The following is a description of a gene set: studied in species Mus musculus from publication Sheth SS, Bodnar JS, Ghazalpour A, Thipphavong CK, Tsutsumi S, Tward AD, Demant P, Kodama T, Aburatani H, Lusis AJ (PMID 16607285) The molecular pathogenesis and the genetic aberrations that lead to the progression of hepatocellular carcinoma (HCC) are largely unknown. Here, we demonstrate that the thioredoxin interacting protein (Txnip) gene is a candidate tumor suppressor gene in vivo. We previously showed that the recombinant inbred congenic strain HcB-19 has a spontaneous mutation of the Txnip gene, and we now show that the strain has dramatically increased incidence of HCC, and that the HCC cosegregates with the Txnip mutation. Approximately 40% of the Txnip-deficient mice developed hepatic tumors with an increased prevalence in male mice. Visible tumors develop as early as 8 months of age. Histological analysis confirmed the morphology of HCC in the Txnip-deficient mice. Molecular markers of HCC, alpha-fetoprotein and p53, were increased in tumors of Txnip-deficient mice. The upregulation of p53 preceded tumor development; however, bromodeoxyuridine (BrdU) labeling of normal hepatic tissue of Txnip-deficient mice did not reveal increased cell proliferation. Finally, microarray analyses of tumor, non-tumor adjacent, and normal tissue of Txnip-deficient mice highlighted the genetic differences leading to the predisposition and onset of HCC. Our findings suggest that Txnip deficiency is sufficient to initiate HCC and suggest novel mechanisms in hepatocarcinogenesis. Mouse Gene Set: SHETH_LIVER_CANCER_VS_TXNIP_LOSS_PAM2 Cluster PAM2: genes up-regulated in hepatocellular carcinoma (HCC) vs normal liver tissue from mice deficient for TXNIP., and this is the list of marker genes: Pold4, Paqr4, Lysmd2, Tubb2a, Ddit3, Abcb1a, Acbd3, Smpdl3b, Scn8a, Eif2ak3, Ccnb1, Pttg1, Slc39a4, Bex2, Myo7b, Uap1l1, Abcc5, Fkbp11, Col4a1, Runx2, Zfp119a, Arhgap18, Cd93, App, Dab1, Vamp5 (NCBI Gene Id 53620), Tagln2, Tle6, Upp1, Rrm2, Twf2, Dip2b, Psrc1, Rogdi, Clcf1, Bmp7, Heph, Slc1a4, Stt3a, Tor4a, H1f2, Wnt10a, Fmnl3, Mcam, Kcnj8, Rasgrp2, Comtd1, Zg16, Rbp1, Cyp39a1, Ptpre, Bicdl1, Fscn1, Tacc3, Xylt2, Ddx25, Nap1l1, Pawr, Sirpa, Tagln, Rab34, Eri2, Dmc1, Meox1, H2ac8, Lgals1, Ctla2a, Cerk, Myo9b, Zfp37 (zinc finger protein 37), Lpl, Dlg4, Sel1l3, Btg3, Wnk4, Vnn1, Tspan8, Slf1, Dynll1, Chmp6, Mvk, Nol12, Dusp6, Svs3a, Acsl4, Ctsg (cathepsin G), Hmmr, Golm1, Snhg1, B4galt6, Rhoc, Peg3, Abcd2, Qser1, Eif2ak4, Cenph, Mcm2, Pofut2, Prrx1, Tuba8, Gsdme, Pnliprp2, Tceal8, Tpm1, Slc12a4, Btg2, Gria3, Ccnd1, Col4a4, Atf3, Il1rn, Miox, Pnpla3, Ska2, Inhbb, Macir, Ccdc96, Pls1, Hsd3b1, S100a11, Cd40, Gjc1, Tnfsf13 (NCBI Gene Id 69583), Elapor1, Agfg1, Cd14, Ajuba, Bcl2l14, Tax1bp3, Rab3c, Rdh9 (NCBI Gene Id 210060), Cox5b, Myadm, Trib3, Ier3, Mal, Plscr1, Cklf (NCBI Gene Id 75458), D17H6S56E-5, Cd276, Rpap3, Nenf (neuron derived neurotrophic factor), Scd2 (NCBI Gene Id 226146), Efnb2, Adgrg1, Rtkn, Morc4, Cystm1, Tanc1, Ddr1, Tceal9, Dnajc10, Fgd1, Nuf2, Dsg2, Akr1b1, Anxa2, Pgm1, Cav2, Prss8, Hid1, Ptgr1, Sparc, Map4k4, Pfkfb3, Lyve1, Npdc1, Unc119, Anxa9, Tgfbr2, Tmem45b, Abhd5, Arhgap12